The following is a description of a gene set: Human Gene Set: HP_FIRST_DEGREE_ATRIOVENTRICULAR_BLOCK Delay of conduction through the atrioventricular node, which is manifested as prolongation of the PR interval in the electrocardiogram (EKG). All atrial impulses reach the ventricles. First degree atrioventricular block species: Homo sapiens, and this is the list of marker genes: GPD1L, DOHH, TBX5, AKAP9, LMNA, KCNE5, KCNK3, PSEN2, KCNE3, DTNA, ACTC1, CACNA2D1, PSEN1, SEMA3A, MYPN, GATA6, SCN5A, SLMAP, CACNB2, SCN3B (NCBI Gene Id 55800), KCND3, KCNJ8, CTNNA3, PKP2, TRPM4, SCN2B, HCN4, MYBPC3, SCNN1A, GJA5, SCN10A (sodium voltage-gated channel alpha subunit 10), MYH6, RANGRF, TBX20 (T-box transcription factor 20), MYL4, SCN1B, CITED2, DMPK, GATA4, EMD, NKX2-5, TLL1, ABCC9, CACNA1C (NCBI Gene Id 775)